The following is a description of a gene set: Understanding the response of memory CD8 T cells to persistent antigen re-stimulation and the role of CD4 T cell help is critical to the design of successful vaccines for chronic diseases. However, studies comparing the protective abilities and qualities of memory and naïve cells have been mostly performed in acute infections, and little is known about their roles during chronic infections. Herein, we show that memory cells dominate over naïve cells and are protective when present in large enough numbers to quickly reduce infection. In contrast, when infection is not rapidly reduced, memory cells are quickly lost, unlike naïve cells. This loss of memory cells is due to (i) an early block in cell proliferation, (ii) selective regulation by the inhibitory receptor 2B4, and (iii) increased reliance on CD4 T cell help. These findings have important implications towards the design of T cell vaccines against chronic infections and tumors. Genes up-regulated in comparison of splenic primary CD8 effector T cells at day 8 post-acute infection versus splenic secondary CD8 effector T cells at day 8 post-acute infection. from publication West EE, Youngblood B, Tan WG, Jin HT, Araki K, Alexe G, Konieczny BT, Calpe S, Freeman GJ, Terhorst C, Haining WN, Ahmed R (PMID 21856186) Human Gene Set: GSE30962_PRIMARY_VS_SECONDARY_ACUTE_LCMV_INF_CD8_TCELL_UP studied in species Homo sapiens, and this is the list of marker genes: BIRC5, GNAI3, TPI1, FLT4, MTFR2, SGO2, SNRPA, CIT, HLA-DOA, IKZF2, KPNA2, MCM10, CENPA, SDF2L1, SELENOH, TEX9, H2AX, CENPF (NCBI Gene Id 51468), CENPN, C4orf46, RAD54L, BUB1B, DLGAP5, KIF20B, ZNF597, CKAP2L, STIL (STIL centriolar assembly protein), NCAPG2, BRCA1 (BRCA1 DNA repair associated), NUF2, IPO11, UGT3A2, CKS1B (CDC28 protein kinase regulatory subunit 1B), HYOU1, DBI, CINP, GTF2E2, HEG1, MOAP1, EOMES, NDUFA4, VWA1, HROB, FAM110C, TMEM97, CENPK, NRP2, PLK4, TMPO, EZH2, CLASP1, NCAPD2, XRCC2, KIF22, SNRNP35, KLHL32, LUZP1, SPC25, TNFRSF9, CENPP (centromere protein P), MGST2, GINS1, PKMYT1, AP1B1, SOCS1, CENPE, AFF3 (NCBI Gene Id 3899), MCM3, TAF1, ASPM, CDCA5, RFX2, FKBP5, AURKB, DEUP1, LIG1, CLSPN, HRH4 (histamine receptor H4), FBXO5, AIDA, HYAL2, MXD3, PPIH, CLTC, NDC80, CCNB2, CCNF, ASAP1, BRIP1, PSPC1, DBF4 (DBF4-CDC7 kinase regulatory subunit), VAV2, TBL1X, ASF1B, TRIP13, C12orf75, BDH1, BUB1, SLC7A1, MIPEP, WDR90, CCNA2, TUBB4B, TCF7, PIF1 (PIF1 5'-to-3' DNA helicase), TOP2A, PPIA, PKP4, CA4, GALNS, NUSAP1, EYA1, MND1, EXO1, KIF23, NEK2, UCP3, MTHFD2, GMNN, EME1, SH3RF1, TCP10L, EIF3C, XCL1, ERO1A, BTLA, PAQR4, CKS2, STT3B, WAS, MIS18BP1, NEIL3, ICOS, IFT80, CDC45, POLE, MCM5, SPC24, KIF4A, SKA1, FIGNL1, TTLL12, ESCO2, RRM2, SMC2, PSAT1, ZAP70, ERCC6L, TTK, NDUFS8, DSCC1, SPEF1, CDCA3, SCN2A, RCBTB2, SHCBP1, UHRF1, AKAP1, ETS2, KPTN, CLPB, MELK, ELF5, IRAK3, PALS2, SPAG5, SIVA1, ARL1, EIF4A1, TK1, RAB11FIP3, CASS4, ESPL1, FGL1, HJURP, PCLAF, MEMO1, ARHGAP19, NCAPH, ARHGAP11A, TICRR (NCBI Gene Id 90381), CDC6, SV2B, GEMIN6, CEP55, FNTB, STMN1, SLC27A5, KALRN, HMGB2, E2F8, RAD51, MRPL51, RRM1, MNS1, KIF18B, KNL1, PARPBP, KIF20A, REXO2